The following is a description of a gene set: Human Gene Set: HP_MULTIPLE_BLADDER_DIVERTICULA Presence of a many diverticula (sac or pouch) in the wall of the urinary bladder. species: Homo sapiens Multiple bladder diverticula, and this is the list of marker genes: MED12, LTBP1, FBLN5, LTBP4, EFEMP2